Given this list of marker genes PAK2, APC2, TMEM67, SOX17, KDM6A, ZMPSTE24, NCAPG2, NODAL, KMT2D, LMNA, TCTN2, B3GLCT, TCTN1, PORCN, B9D1, CEP290, PSMD12, PBX1, TMEM231, CSPP1, RBM8A, FIBP, GPC3, TMEM237, CPT2, COL18A1, FUZ, RPGRIP1 (NCBI Gene Id 57096), AXIN1, GPC4, TCTN3, KCTD1, B9D2, GATA6, TMEM107, TXNDC15, RPGRIP1L, IFT140, CC2D2A, SPINT2, PIGN, SOS1 (SOS Ras/Rac guanine nucleotide exchange factor 1), NSD1, TMEM216, VANGL1, SLC6A17, MKS1, here is a description of the gene set: studied in species Homo sapiens A developmental anomaly characterized by the presence of two, instead of one, ureter connecting a kidney to the bladder. Ureteral duplication Human Gene Set: HP_URETERAL_DUPLICATION